The following is a description of a gene set: Genes negatively differentially expressed in cell type: B cell upon treatment with cytokine: IL-1β in mouse lymph nodes in vivo. Cytokines mediate cell-cell communication in the immune system and represent important therapeutic targets. A myriad of studies have highlighted their central role in immune function, yet we lack a global view of the cellular responses of each immune cell type to each cytokine. To address this gap, the authors created the Immune Dictionary, a compendium of single-cell transcriptomic profiles of more than 17 immune cell types in response to each of 86 cytokines (>1,400 cytokine-cell type combinations) in mouse lymph nodes in vivo. A cytokine-centric view of the dictionary revealed that most cytokines induce highly cell-type-specific responses. For example, the inflammatory cytokine interleukin-1β induces distinct gene programmes in almost every cell type. A cell-type-centric view of the dictionary identified more than 66 cytokine-driven cellular polarization states across immune cell types, including previously uncharacterized states such as an interleukin-18-induced polyfunctional natural killer cell state. studied in species Mus musculus Mouse Gene Set: CUI_B_CELL_IL1B_RESPONSE_DN from publication Cui A, Huang T, Li S, Ma A, Pérez JL, Sander C, Keskin DB, Wu CJ, Fraenkel E, Hacohen N (PMID 38057668), and this is the list of marker genes: Igkc, Ltb, Ier5, Iglc2, Klf2, Cd79b, Iglc3, Fth1, Fcer2a